Given this list of marker genes Slc1a2, Sh2b2, Tspan5, Adcy6, Eapp, Herpud1, Myh10, Cd3g, Nr3c1, Trpa1, Fbxo4, Erlin1, Lce1l, Tm9sf3, Adgrg6, Art4, Pik3r1, Ptprg, Myct1, Zfp804a, Asxl2, Csde1, Fam20c, Zwint, Tmem14c, Larp4, Hepacam2, Ptgs1, Zfp280d, Pcmtd1, Ccn1, Xbp1, Gapvd1, Clta, Selenop, Tsc1, Alkal2, Mttp, Slc19a3, Ube2k, Ubqln2, Pxdn, Pals1, Nkain2 (NCBI Gene Id 76197), Atrx, Fabp5, Dnajc21 (NCBI Gene Id 78244), Rarres1, Mex3b, Dnaaf9, Mapre1, Rer1, Xpnpep1, Entpd6, Mob1b, Dennd1b, Zhx1, Smco4, Rimkla, Tmem263 (NCBI Gene Id 103266), Eif4e, Ndufv2, Zic3 (zinc finger protein of the cerebellum 3), Ddx3x, Tmem19, Tcf20, Pou2f1, Zfp810, Plekhh1, Onecut2, Pcmtd2, Zfp420, Kcnab1, Cks2, Nap1l1, Myocd, Fem1c, Dcp2, Tbc1d8b, Dusp6, Slc44a4, Mesd, Kcns3, Zdhhc20, Yod1, Ak4, Itgb8, Dhfr, Vsnl1, Stx7, Trappc6b, Slc31a1, Arid1a, Gucy1a2, Tmem26, Sema3c, Rap2c (RAP2C, member of RAS oncogene family), Ncf1, Plcxd3, Ninl, Grm5, Rhbdl3, Ccdc146, Snx30, Apod, Amdhd1, Zbtb21, Mtmr4, Kif5b, Matr3, Prkci, Fam135a, Pkn2 (NCBI Gene Id 99668), Sox21, Wdsub1, Pstpip2, Foxj3, Dr1, Tnrc6b, Fut9, Impact, Pcdh19, Meis2, Fbxw11, Braf, Serbp1, Trp53rkb (transformation related protein 53 regulating kinase B), Mamdc2, Slco1c1, Flrt1, Uqcc5, Ccser1, Pdia6, Zmym6, Ostn, Or4a73, here is a description of the gene set: from publication Chen Y, Wang X (PMID 31504780) Mouse Gene Set: MIR_181B_1_3P_MIR_181B_2_3P species: Mus musculus Genes predicted to be targets of miRBase v22 microRNA mmu_miR_181b_1_3p, mmu_miR_181b_2_3p in miRDB v6.0 with MirTarget v4 prediction scores > 80 (high confidence targets).